Given this list of marker genes Ndn, Ttc8, Tspan2, Shtn1, Fgf8, Map1b, Arhgap35, Slitrk5, Cacna1f, Wnt3a, Zpr1, Or10a4, Trim46, Gli3, Bmp7, Gap43 (NCBI Gene Id 14432), Ntn5, Lmx1a, Nog, Phox2b, Ncam2, Drgx, B4gat1, Mir200a (NCBI Gene Id 387242), Diaph2, Lama3, Vash2, Casp6, Atoh1, B3gnt2, Sipa1l1, Bmpr1b, Foxd1, Rpl24, Flrt3, Shox2, Als2, Nr2e1, Slitrk4, Sema6a, Diaph1, Actbl2, Cntn6 (contactin 6), Myot, Isl1, Bcl11b, Tbce, Ablim1, Cnr1, Adarb1, Ulk1, Atoh7, Plxnb2, Ngf, Islr2, Mir376a (microRNA 376a), Map6, Dcx, Metrn, Rnd2, Braf, Nkx2-9, Prkg1, Nefm, Kif5b, Trpc5, Ret, Klf7, Apoa1 (NCBI Gene Id 11806), Vegfa, Olfm1, Adcy10, Mef2c, Kel, Nfasc, Apbb1, Ntng1, Ptprz1, Lhx2, Grn, Wdr36, Nlgn3, Nova2, Wnt3, Neurod4, B4galt5, Csf1r, Nectin1, Ulk2, Lgr4, Fkbp1b, Slc25a46, Uchl1, Sema6c, Lgi1, Disc1, Ptprj, Wnt7a, Ap5z1 (adaptor-related protein complex 5, zeta 1 subunit), Tspo, Rac1, Dcc, Sema5a, Ntf3, Cdkl3 (NCBI Gene Id 213084), Gbx1, Tnr, Arx, Igfals, Pafah1b1, Epha10, Mgll, Dst, Mypn, Map2, Nptn, Atl1, Unc5b, Rtn4rl1 (reticulon 4 receptor-like 1), Sema3b, Fgfr2, Nkx2-1, Ttl, Rufy3, Cntn5, Flrt2, Itga4, Fgf13, Efna5, Olig1, Prkca, Hdac6, Ntrk2, Ncam1, Mycbp2, Xk, Kalrn, Sema7a, Dpysl5, Bcl11a, Robo2, Plxna4, Apoe, Eif4g2, Lhx3, Robo3, Sema4a, Twf2, Tnc, Cdk5, Dixdc1, Lrp2, B4galt6, Actb, Ntn1, Ark2c, Chn1, Grm7, Vim, Lmtk2, Lama2, Nefl (neurofilament, light polypeptide), Ndp, Nrn1, Efnb1, Nrp2, Mir9-1 (microRNA 9-1), Pou3f2, Megf8, Abl1, Nkx6-1, Pak1 (p21 (RAC1) activated kinase 1), Isl2, Map1a, Ece1, Kcna1, Ctnna2, Stmn1, Gata3, Cttn, Trpv2 (NCBI Gene Id 22368), Nefh, Smo, Bcl2, Ndel1, Xylt1, Spg11, Edn3, Lamb2, Lhx4, Dynlt1c, Sema3g, Srf, Gas1 (NCBI Gene Id 14451), Bhlha15, Mag, Pou4f2, Ddr1, Kif5c, Foxb1, Rab3a, Fezf1, Limk1, Unc5d, Skil, Plxnb3, Stxbp5, Dynlt1b, Arhgap32, Cdk5r2 (NCBI Gene Id 503689), Tgfb2, Hoxa1, Szt2, Tbr1, Wdr47, Nfix, Thy1, Pak3, Trak1 (NCBI Gene Id 67095), Dynlt1f, Pip5k1c, Jun, Notch3, Nrep, Sema6b, App, Ptprv, Fn1, Ptk2, Wnt5a, Ythdf1 (YTH N6-methyladenosine RNA binding protein 1), Rtca, Ccr5, Camsap2, Lamc3, Olig3, Sema3a, Trim32, Epha6, Sema5b, D130043K22Rik, Ache, Slitrk6, Cyfip2 (cytoplasmic FMR1 interacting protein 2), Dnm2 (dynamin 2), Picalm, Sin3a, Celsr3, Dvl1, Shh, Afg3l2, Adcy1, Dscam, Npr2, Matn2, Neurog3, Lamc1, Scarf1, Robo1, Ntrk1, Mir124a-2, Slc9a6, Epha3, Ednra, Lrrc4c, Stk24, Efna4, Sema3c, Svbp (NCBI Gene Id 69216), Fezf2, Nptx1, Gfra3, Etv4, Dip2b, Ist1, Cdh2, Ntn3, Epha7, Fbxo45, Nrp1, Gdf7, Psen1, Lrp4, Dab1, Chl1, Rab21, Rgma, Clasp2, Otx2, Foxp1, Cdk5r1, Neurod6, Nrg1, Edn1 (NCBI Gene Id 13614), Ctnna1 (catenin alpha 1), Prtg, Cacna1a, Cdh1, Smurf1, Tubb2b, Gli2, Tfap4, Rab8a, Mir200b, Efnb3, Cxcl12, Wnt7b, Plppr4, Apc, Trio, Borcs7, Tsc2, Pcdhac2, Mnx1, Draxin, Zdhhc17, Chodl, Evl, Pax6, Spg21 (NCBI Gene Id 97525), Dag1, Reln, Apbb2, Ttc3, Efna3, Evx1, Crabp2, Egr2, Vcl, Tiam1, Grin1, Eif2b2, Fam168b, Stxbp1, Rtn4rl2, Tnfrsf21, Flna, Bhlhe22, Nfib, Dbn1, Pten, Cdh11, Mtr, Zfyve27, Sema4f, Tnn, Cntnap2, Plp1, Lpar3, Epha8, Kifc2, Ptprm, Plxnd1, Bmpr2, Neurod1, Spart, Mt3, Lrp1, Inpp5f, Unc5a, Epb41l3, Rnf6, Pum2 (pumilio RNA-binding family member 2), Ephb3, Cntnap1, Foxg1, Vax2, Efnb2, Omg, Golga2, Dock7, Dynlt1a, Sptbn4, Ephb1, Lamb3, Sema4g, Cckar, Ptch1, Nrcam, Auts2, Lrig2, Zeb2, Epha4, Creb1, Gbx2, Or8a1b, Vangl2, Lhx1, Taok2, Ntn4, Zic2, Slit1 (slit guidance ligand 1), Fxn, Map1s, Boc, Map2k1, Aplp1, Olig2, Tctn1, Kif21a, Nr4a2, Slit3, Prickle1 (prickle planar cell polarity protein 1), Mgarp, Neurog1, Erbb2, Itgb1, Rac3, Ntng2, Cntf, Ext1, Spast, Slit2, Lama1, Stk11 (NCBI Gene Id 97678), Gdi1, Cobl, Folr1, Usp9x, Rpl4 (NCBI Gene Id 67891), Lamb1, Acte1, Adam17, Mapk8ip3, Gm2990, Lamc2, Igf1r, Ptprh, Sema3f, Numbl, Cck, Raph1, Map2k2, Usp33, Pou4f3, Atg7, Cd2ap, Vasp, Gpm6b, Trak2, Lmo4, Tnfrsf12a, Barhl2, Sema3d, Chrnb2, Etv1, Enah (NCBI Gene Id 98642), Atp8a2, Alcam, Actg1, Bex1, Neurog2, Rab10, Cntn1, Myo5b, Artn, Crtac1, Cdkl5, Arhgef28, Plxnb1, Pmp22, Cspg5, Ntrk3, Emb, Gsk3b, Cxcr4, Mbp, Arhgef25, Dbnl, Col25a1, Snap25, Mir200c, Sema3e, Gdnf, Slitrk2, Enpp1, Tubb3, Mark2, Map3k13, Drd2, Ryk (NCBI Gene Id 20187), Grcc10, Ep300 (NCBI Gene Id 328572), Neo1, Casp3 (caspase 3), Pla2g10, Epha5, Lhx9, Kifbp, Septin7, Prdm8, Cntn2, Sema4c, Mapt, Gla, Nrdc (NCBI Gene Id 76534), Ptpn11, Efna1 (ephrin A1), Bsg, Efna2 (ephrin A2), Tbc1d24, Dclk1, Fzd3, Kif5a, Syngap1, Pak2, Megf9 (NCBI Gene Id 71014), Apod, Cnp, Scn1b, Lama5, Notch1, Numb, Brsk2 (NCBI Gene Id 75770), Ephb6, C9orf72, Slitrk1, Pitpna, Adnp, Actr3, Klf4, Crppa, Brsk1, Dhfr, Sema4d, Neurod2, Apoa4, L1cam, Anapc2, Fstl4, Cyfip1, Edn2, Flot1, Scn11a, Plxnc1, Mir9-3, Nell2, Bdnf, Mmp2, Golga4, Nr4a3, Ngfr, Nin (NCBI Gene Id 73198), Macf1, Rtn4, Top2b, Myh10 (NCBI Gene Id 77579), Sema6d, Amigo1, Mir124a-1, Rtn4r, Bhlhe23, Arhgap4, Smad4, Ank3, Sema4b, Snap91, Agrn, Dubr, Aplp2, Slitrk3, Cers2, Runx3, Dlx5, Kif13b (NCBI Gene Id 77105), Llgl1, Jak2 (NCBI Gene Id 98155), Smn1, Ptprf, Kremen1, Ephb2, Hoxa2, Fgfr3, Stk25, Cdh4 (NCBI Gene Id 99327), Vax1, Ptpro, Ptn, Tsku, Plxna3, Mir9-2, Ptprs, Ilk, Tiam2, Nexn, Ssna1, Dscaml1, Ust, Unc5c, Ifrd1, here is a description of the gene set: The progression of an axon over time. Covers axonogenesis (de novo generation of an axon) and axon regeneration (regrowth), as well as processes pertaining to the progression of the axon over time (fasciculation and defasciculation). Mouse Gene Set: GOBP_AXON_DEVELOPMENT species: Mus musculus